The following is a description of a gene set: from publication Zha Y, Marks R, Ho AW, Peterson AC, Janardhan S, Brown I, Praveen K, Stang S, Stone JC, Gajewski TF (PMID 17028589) compare gene expression profiles between normal and anergic T cells and identify upregulated genes in anergic T cells Genes down-regulated in comparison of anergy induced CD4 T cells versus conventional CD4 T cells. Human Gene Set: GSE5960_TH1_VS_ANERGIC_TH1_DN species: Homo sapiens, and this is the list of marker genes: F11R, MECP2, SCP2, PTPRS (NCBI Gene Id 5802), EED, ARL3, AMELX, RHOQ, FGF1, BIN1, ANXA7, PRKCD, SDF4, CHP1, CD81, GRB2, SQOR, MEMO1, SRPK2, PRKACA, RPN2 (ribophorin II), TUBB, CD2BP2, PPP1R7, CCL5, REPS1, SMARCC1, MAP2K1, CYB5A, DPF3, S100A1, STAT6, RBL1, SLC25A20, AAMP, HPS4, CYBA, TTC7B, PROX1, ID1, CXXC5, LGALSL, ABCC1, EIPR1, TMEM245, ADSS1, CST7, FAM89B, NFKB2, GABARAPL2 (GABA type A receptor associated protein like 2), SLC41A1 (solute carrier family 41 member 1), MDK, CD6, SERPINE2, POLR2G (NCBI Gene Id 5436), BRCA1, TM7SF3, TNFRSF9, CYB5R3, SLC29A1, SCG2, PLXND1, NRGN, SLC7A3, ATP6V0B, ECM1, YWHAH, ITIH5, ZSWIM7, ADPRH, LRP10, PTP4A2, ITFG1, TPRA1 (transmembrane protein adipocyte associated 1), ACOT7, CYFIP1, FUBP1, TOB1, GABARAPL1, NUP93, CORO1C, CDH8, NCK2, PAFAH1B2, APOC4, KANK3 (KN motif and ankyrin repeat domains 3), C5orf15, PHKA2, ECH1, NEK7, RNASET2, SHOX2, CSF2 (colony stimulating factor 2), AVP, ATF6B, GDI1, PRKCA, DTX2, DLGAP4, HGFAC (HGF activator), POLD4, CSTB, MTF2, CAPN1, FBXO3, HOPX, SLC5A1, FCGR2A, AP4S1, TMBIM1, CCDC90B, PTOV1, PDPK1, NDUFA6, AP3S1, PITPNM1, PIGQ, TXNDC16, SLC44A1, SLC48A1, MRPS25, SEMA7A, TSHB, REEP5, CHCHD7, PNPLA2, CD68, AP3B1, ITGB2, CYSTM1, LONP2, HCFC1, NAPSA, ORMDL1 (NCBI Gene Id 94101), RNH1, CSNK1D, NKX2-8, IER3, UBE2V1, ANXA5, GNPDA1, PDK3, SLC52A2, SLC12A4, TNPO2, F2RL1, ATP5F1D, MDM2, TSFM, EMC3, PLS3, ATP6V1E1, FBXW11, PYCR2 (pyrroline-5-carboxylate reductase 2), SYT11 (NCBI Gene Id 92303), TEC, IGF1, IAPP, TMEM109, OTUD7B, CCNE1, FANCM, KMT5A, GK, PRAP1, NPC1, PTGER3, ALOX12B, TMEM126A, PAPSS1, CTNNA1, APEX1, HIVEP1, PIP5K1A, VAMP5, TNFRSF8, SNX9, AMZ2, ASS1, CAPN5, AHCYL1, TRPC4AP, ATXN10, RNF19A, ITGAV, TNFRSF18, ST6GALNAC6, PEX19, CREB3L1, HAS1, NFE2L1, S100A3, NEK6, UBE2N, LCLAT1, ACP1, TES, CPT1A, RGS16, PCM1